Given this list of marker genes Obsl1, Defb19, Serpina1a (NCBI Gene Id 544889), Tuba1a, Scarf2, Hnrnpdl, Afp, H2ac10, H2ac24, H2ac12, Pdgfa, Atp12a, Uhrf1, Ccna2, Cldn11, Rrm1, Ndp, Tubb5, Rps6, here is a description of the gene set: Mouse Gene Set: PIONTEK_PKD1_TARGETS_DN from publication Piontek K, Menezes LF, Garcia-Gonzalez MA, Huso DL, Germino GG (PMID 17965720) studied in species Mus musculus Genes down-regulated during later stages of renal maturation (days P14-P16) in kidney specific knockout of PKD1. Autosomal dominant polycystic kidney disease is an important cause of end-stage renal disease, for which there is no proven therapy. Mutations in PKD1 (the gene encoding polycystin-1) are the principal cause of this disease. The disease begins in utero and is slowly progressive, but it is not known whether cystogenesis is an ongoing process during adult life. We now show that inactivation of Pkd1 in mice before postnatal day 13 results in severely cystic kidneys within 3 weeks, whereas inactivation at day 14 and later results in cysts only after 5 months. We found that cellular proliferation was not appreciably higher in cystic specimens than in age-matched controls, but the abrupt change in response to Pkd1 inactivation corresponded to a previously unrecognized brake point during renal growth and significant changes in gene expression. These findings suggest that the effects of Pkd1 inactivation are defined by a developmental switch that signals the end of the terminal renal maturation process. Our studies show that Pkd1 regulates tubular morphology in both developing and adult kidney, but the pathologic consequences of inactivation are defined by the organ's developmental status. These results have important implications for clinical understanding of the disease and therapeutic approaches.